Given this list of marker genes KMT2D, ZIC2, PLCH1, FGF8, SIX3, STIL, SMC1A, DISP1 (dispatched RND transporter family member 1), TGIF1, GAS1, CRIPTO, PTCH1, KDM6A, DLL1, CDON, STAG2, FGFR1 (NCBI Gene Id 84151), FOXH1, GLI2, NODAL, SHH, here is a description of the gene set: Proboscis A fleshy, tube-like structure usually located in the midline of the face or just to one side of the midline. Human Gene Set: HP_PROBOSCIS species: Homo sapiens